Given this list of marker genes CTLA4, HLA-DPA1, HLA-DPB1, PRTN3, PTPN22, here is a description of the gene set: studied in species Homo sapiens Anti-neutrophil elastase antibody positivity Human Gene Set: HP_ANTI_NEUTROPHIL_ELASTASE_ANTIBODY_POSITIVITY The presence of autoantibodies (immunoglobulins) in the blood circulation that react against neutrophil elastase.